The following is a description of a gene set: from publication Chen Y, Wang X (PMID 31504780) Human Gene Set: MIR3605_5P Genes predicted to be targets of miRBase v22 microRNA hsa-miR-3605-5p in miRDB v6.0 with MirTarget v4 prediction scores > 80 (high confidence targets). species: Homo sapiens, and this is the list of marker genes: IRX2-DT, PRKACG, CX3CL1, GTF2H1, MSTO1 (NCBI Gene Id 55154), CFAP92, TXLNG, NSD1, CYGB, MBD2, CBFA2T3, CLRN1, ATN1, MEX3C, DARS2, SLC43A2, KRTAP9-8, TSR1, UTY, CFAP184, GRIN3A, TMOD2, SPATA31D4, KCNK5, NRG3, FCGR3B, EOMES, UBP1 (upstream binding protein 1), ZNF426, NLRX1, ADORA3, BCAM, PLCG1, FAM169BP, ZNF285, ZNF737 (NCBI Gene Id 7655), KLK5 (kallikrein related peptidase 5), FAS, LZTS1, LYRM1, TMEM254, NRROS, STX5 (NCBI Gene Id 6811), CASTOR3P, RNF157, HMGN3, CASK, FCGR3A, LRTOMT, GATAD1, KIAA0408, KCNQ3, RINT1, C4BPA, COX15, RUNX1, NOLC1, SLC6A1, KRTAP9-2, IBSP, ZNF322, TSHZ2, DCAF10, IFT88, STXBP1, NOVA1, SMG7, IRX4, KIAA0753, SPATA31D3, DDT, KRTAP9-3, RAB6B, ABCA9, NALF2, PPM1A, ABLIM2, CDKN2AIP, SEMA3A, POU2F2, RAB3C, ARL6IP6, CD93 (CD93 molecule), GUCY1A1, RUNX1T1, FOXO1, SLC6A17, CHRM1, APOLD1 (NCBI Gene Id 81575), KLHDC10